Given this list of marker genes Egfr, Cyp1a1, F7, Cat, Ugt3a2, Ugt3a1, here is a description of the gene set: Mouse Gene Set: GOBP_RESPONSE_TO_PHENYLPROPANOID studied in species Mus musculus Any process that results in a change in state or activity of a cell or organism (in terms of movement, secretion, enzyme production, gene expression, etc.) as the result of a phenylpropanoid stimulus. The process begins with detection of the stimulus and ends with a change in state or activity or the cell or organism. A phenylpropanoid is any of secondary metabolites with structures based on a phenylpropane skeleton. The class includes phenylpropanoid esters, flavonoids, anthocyanins, coumarins and many small phenolic molecules. Phenylpropanoids are also precursors of lignin.